The following is a description of a gene set: from publication Gentles AJ, Plevritis SK, Majeti R, Alizadeh AA (PMID 21177505) Genes down-regulated in LSC (leukemic stem) cells compared to LPC (leukemia progenitor) cells from AML (acute myeloid leukemia) tumor samples. studied in species Homo sapiens Human Gene Set: GENTLES_LEUKEMIC_STEM_CELL_DN In many cancers, specific subpopulations of cells appear to be uniquely capable of initiating and maintaining tumors. The strongest support for this cancer stem cell model comes from transplantation assays in immunodeficient mice, which indicate that human acute myeloid leukemia (AML) is driven by self-renewing leukemic stem cells (LSCs). This model has significant implications for the development of novel therapies, but its clinical relevance has yet to be determined., and this is the list of marker genes: PCLAF, MND1, DLGAP5 (DLG associated protein 5), SKA3, CLC, IL36B, DDX53, MS4A3, STAR, RNASE2, RNASE3, CPA3, CCL5, CCNA1, CSTA (cystatin A), OLFM4, ZWINT, CD38, ANLN